The following is a description of a gene set: studied in species Mus musculus Mouse Gene Set: TABULA_MURIS_SENIS_SPLEEN_MACROPHAGE_AGEING from publication Tabula Muris Consortium (PMID 32669714), and this is the list of marker genes: Gng11, C1qa, Aldh2, Ifitm1, Smagp, Ly6a, Psma5, Ctsc, Smdt1, Slc25a5, S100a8, Cfp, Hexa, Atp6v0e, Lamp1, Mpeg1, Tmem176b, Ptpn1, Plaat3, Fth1, Lyz2, Prdx5, Zfas1, Cstb, Elob, Rpl39, Atp2b1, Slc3a2, Csnk2b, Blvrb, Derl1, Rabac1, Lgmn, H2aj, Tmed3, Aldoa, Slirp, Tmem176a, Slpi, C1qc, H2bc4, Selenop, App, Rnasek, Fcer1g, Csf1r, Itm2b, Ndufv3, Basp1, Ctla2a, P4hb, Ctsb, Lamp2, Cox8a, Rgs10, Fabp5, Gapdh, Clec4a2, Acp5, Pf4, Cd81, S100a9, Sod1, Scand1, Msrb1, Rps27l, Akr1a1, Vamp8, Prdx2, Tmem14c, Ctss, Litaf, Il1b, Cd300c2, Prdx1 (NCBI Gene Id 18477), AW112010, St13, Atp6ap1, Cybb, Atp5mc1, Tspo, Npc2, Cmtm7, Lyz1 (NCBI Gene Id 17110), Mt1, Rbm3, Apoe, Ebp, Ppbp, Wfdc17, Ninj1, Ctsd, Stmp1, Vcam1, Aif1, Mrpl52, Smpdl3a, Wnk1, Tmed10, Flna, Ftl1, Creg1, Tln1, Rsrp1, Ndufa1, Atp1b3 (ATPase, Na+/K+ transporting, beta 3 polypeptide), Sat1, Gabarap (NCBI Gene Id 56486), Jchain, Spg21, Sh3glb1, Reep5, C1qb, Cd63, Rpp21, Trf, Lgals1, Tmbim4, Grn, Txn1, Ifitm2